The following is a description of a gene set: studied in species Homo sapiens Genes predicted to be targets of miRBase v22 microRNA hsa-miR-4746-5p in miRDB v6.0 with MirTarget v4 prediction scores > 80 (high confidence targets). from publication Chen Y, Wang X (PMID 31504780) Human Gene Set: MIR4746_5P, and this is the list of marker genes: SLC25A44, NR2C2, SRF, MAP3K7, SCLY, KTI12 (KTI12 chromatin associated homolog), SRSF8, ELF4, TMCO1